The following is a description of a gene set: Human Gene Set: REACTOME_ORC1_REMOVAL_FROM_CHROMATIN Orc1 removal from chromatin studied in species Homo sapiens, and this is the list of marker genes: CDK2, UBB, CDT1, PSMC6, ORC4, PSMB7, PSMB5, SKP2, PSMB4, PSMD2, MCM5, PSMA7, SKP1, RPS27A, ADRM1, MCM2, CUL1, PSMA1, PSMC2, PSMD13, CDC6, PSMD1, PSMD8, MCM8, ORC2, RBX1, ORC5, PSMB1, PSMC1, PSMB2, PSMA6, MCM3, PSMD7, UBC, MCM4, UBA52, PSMA3, ORC3, PSMD3, ORC6, MCM6, PSMD12, ORC1, SEM1, PSMA5, PSMD11, PSMC5, PSMA4, PSMB6, PSMD6, CCNA2, PSMA2, PSMD14, PSMC3, CCNA1, MCM7, PSMB3, PSMC4